Given this list of marker genes GBP1 (guanylate binding protein 1), UBR2, LILRB4, CSK, ADA, RAB29, RPS3, CD81, PTPN22, LCK, PVRIG, BTN2A2, RC3H1, CD300A, PTPRJ, KCNN4, PTPN2, CBLB, CEACAM1, PAWR, MALT1, SLA2, CCR7, THY1 (Thy-1 cell surface antigen), NCK1, BTRC, CD226, CYLD, ITPRIPL1, PTPRC, PTPN6, ELF1, UBASH3A, NECTIN2, DGKZ, IKBKG, DUSP3, EZR, TRAT1, SH2D1A, DUSP22, BTNL2, LGALS3, CARD11, TESPA1, PRKD2, LAPTM5, LIPA, RELA, CD160, PHPT1, PRNP, BCL10, here is a description of the gene set: Any process that modulates the frequency, rate or extent of signaling pathways initiated by the cross-linking of an antigen receptor on a T cell. Human Gene Set: GOBP_REGULATION_OF_T_CELL_RECEPTOR_SIGNALING_PATHWAY species: Homo sapiens